Given this list of marker genes PTGER3, HPGD, PTGER1, PTGER2, PTGER4 (NCBI Gene Id 5734), here is a description of the gene set: studied in species Homo sapiens Combining with prostaglandin E (PGE(2)) to initiate a change in cell activity. Human Gene Set: GOMF_PROSTAGLANDIN_E_RECEPTOR_ACTIVITY